The following is a description of a gene set: Binding to a protein upon methylation of the target protein. Human Gene Set: GOMF_METHYLATION_DEPENDENT_PROTEIN_BINDING studied in species Homo sapiens, and this is the list of marker genes: FAM156A, CBX5, KMT2E, ZMYND11, BPTF, L3MBTL1, ING1, ING4, SPIN2B, SPIN3, SGF29, CBX2, PHF20L1, MORC4, TP53BP1, L3MBTL2, MORC3 (NCBI Gene Id 23515), SPIN4, ING5, CXXC1, DPPA3, ATRX, CDYL, CDYL2, ZCWPW1, ZMYND8, CBX6, PHF19 (PHD finger protein 19), PHF1, CBX1, SPIN2A, CBX3, SPIN1, FAM156B, RRP8, MBTD1, L3MBTL3, SETD5, CBX8, ING3, ZCWPW2, UHRF1, MPHOSPH8, ING2, EED, PHF13, MTF2, PHF8